Given this list of marker genes MIR17, IER3, MPV17L, BCL2L1, SLC25A6, HEG1, BOK, SLC35F6, FZD9, ARHGAP11B, MIR146A, SLC25A31, GCLC, SLC25A5, NOL3, BAK1, HK2, ACAA2, HSPA1A, SLC25A4, BNIP3, TMEM14A, RASIP1 (NCBI Gene Id 54922), here is a description of the gene set: species: Homo sapiens Human Gene Set: GOBP_NEGATIVE_REGULATION_OF_MEMBRANE_PERMEABILITY Any process that stops, prevents or reduces the frequency, rate or extent of the passage or uptake of molecules by a membrane.